The following is a description of a gene set: Human Gene Set: GOBP_POSITIVE_REGULATION_OF_NEURON_MIGRATION Any process that activates or increases the frequency, rate or extent of neuron migration. studied in species Homo sapiens, and this is the list of marker genes: FLNA, RAPGEF2, NIPBL, TBC1D24, KIF20B, WDR62 (NCBI Gene Id 4181, WD repeat domain 62), RELN, PLAA, NSMF, DAB2IP, DRD1, MDK, SRGAP2C, SHTN1, ZNF609, ARHGEF2, SEMA6A (NCBI Gene Id 57556)